The following is a description of a gene set: Mouse Gene Set: chr18D1 studied in species Mus musculus, and this is the list of marker genes: Dmxl1, Hsd17b4, Fam170a (family with sequence similarity 170, member A), Gm1859, Gm4950, Gm25785, Tnfaip8, Prdm6, Zfp474, Snx2, Gm50457, 1700034E13Rik, Cd63-ps, Sncaip, C030005K06Rik, Ppic, Srfbp1, Prr16, Gykl1, Gm5507, Gm41724, Snx24, Csnk1g3, Gm8572, Cep120, Lox, Gm8529, Gm19466, Gm3815, Pudp, Ftmt, 1700065O20Rik